Given this list of marker genes Htr7, Ano1, Chrna5, Cxcl12, Scn11a, Bace1, Kcna1, Fyn, Grin2a, Tnf, Ntrk1, Trpa1, Phf24 (PHD finger protein 24), Il18, Scn1a, Cxcr4 (NCBI Gene Id 12767), Grin2d, Cacnb3, Tmem120a, Itga2, Tlr4, Htr2a, Grm8, Asic3, Grin2b, Pawr, here is a description of the gene set: Mouse Gene Set: GOBP_DETECTION_OF_MECHANICAL_STIMULUS_INVOLVED_IN_SENSORY_PERCEPTION_OF_PAIN species: Mus musculus The series of events involved in the perception of pain in which a mechanical stimulus is received and converted into a molecular signal.